Given this list of marker genes Efna5, Ngf (nerve growth factor), Crabp2 (cellular retinoic acid binding protein II), Dcx, Sema4d, Wnt3a, Bcl11a (BCL11 transcription factor A), Lpar3, Rnd2, Ist1, Lrp1, Wnt3, Bdnf, here is a description of the gene set: studied in species Mus musculus Mouse Gene Set: GOBP_POSITIVE_REGULATION_OF_COLLATERAL_SPROUTING Any process that activates or increases the frequency, rate or extent of collateral sprouting.